The following is a description of a gene set: species: Homo sapiens Neighborhood of FEN1 flap structure-specific endonuclease 1 in the MORF expression compendium Neighborhood of FEN1 Human Gene Set: MORF_FEN1, and this is the list of marker genes: ALG8, KPNA2, MCM3, MCM6, SRSF1, ESPL1, CCT3, HSPA9, HNRNPAB, NAA10, HAT1, SOD1, PSMB2, HDDC2, EIF4G1, VBP1, H2AZ1, SNRPA1, GSPT1, LSM4, EIF3B, UNG, CHERP, RFC2, MCM7, AHSA1, PCLAF, BAZ1B, TARDBP, HSPA4, RBM14, PTPN11, PCNA, NUDC, CYCS, CDK4, ZWINT, FOXM1, SSBP1, CCT2, CSNK2B, DDX1, BUB3 (BUB3 mitotic checkpoint protein), HSPE1, LMNB2, NUP205, PPM1G, POLR2I, TRIM28, HCCS, DNAJC9, ACOT7, VDAC1, CCNB1, FEN1, HNRNPA3P1, NHP2, CCT5, MTHFD1, DHX16, MFAP1, NSDHL, ATP5PF, ATP5MC3, RRM1